Given this list of marker genes PTX3, DUSP1, NPL, HAL, DRAM1, CYP1B1, MARCO, CD63, SMARCD3, STAB1, SDCBP, SERPINA1, C5AR1, S100A8, CHST15, LILRB2, HCAR3, BLVRA, RRAGD, KLF7, F5, EVI2A, PRRG4, FUCA1, SIPA1L1, PILRA, TSPAN14, PLA2G7, HLA-B, MKNK1, ITM2B, PDE6H, ENC1, SLCO3A1, SAT1, HNMT, NCF2, CDA, TMEM127, FTL, LAMP1, ZNF185, PIK3IP1 (phosphoinositide-3-kinase interacting protein 1), GIMAP5, IRAK3, EGR1, IER3, S100A12, GASK1B, MID1IP1 (NCBI Gene Id 58526), SQSTM1, CDC42EP3, PYGL, ELL2, S100A9, ARAP3, FCN1, RIN2, HLA-F, APLP2, IFFO1, ADGRE1 (adhesion G protein-coupled receptor E1), CD68, BST1, LILRA5, HMOX1, ZDHHC7, G0S2, TOM1, SMPDL3A, NCF1C, ASAH1, CYBB, QPCT, FCAR, NAAA, MPP1, CD163, ZFP36L1, CKAP4, VAMP3, KLF2, CNIH4, AGFG1, CYP27A1, SLC11A1, BTG2, PTGER2, RHOA, ARHGEF10L, HLA-A, RTN3, ALDH1A1, CTSB, ATP6AP2, MXI1, CLEC7A, BIN2, APOBEC3A, LIN7A, FCGR2A, MCOLN1, CD36 (NCBI Gene Id 948), METTL9, MSRB1, CEBPB, VNN2, MTMR3, SASH1, SORL1, CXCL1, PSAP, NFKBIA, GIMAP4, LGALS3, CRISPLD2, CREG1, TCF7L2, BEST1, GRK5, TMBIM1, NINJ1, AIF1, LHFPL2, FXYD6, THEMIS2, GLUL, PLBD1, PELI1, PLCB1, SYPL1, BNIP3L (NCBI Gene Id 9257), FRY, LAIR1, CXCL2, EXT1, CXCL8, DUSP6, UBE2D1, PDXK, VCAN, UTRN (utrophin), CDIPT, CD44, SNX2, SIRPB1, CR1, FOLR2, KIAA0513, GLRX, CD46, SOD2, ACSL1, CSF3R, CANT1, STEAP4 (NCBI Gene Id 79689), CTSD, C3AR1, MANBA, CAST, TNFRSF1B, ATP6V1B2, FBN2, FUT4 (NCBI Gene Id 2526), NCF4, ATXN1, TREM1, CLMN, CLIP4, CD14, IGF2R, GNS, NPC2, CTSS, TKT, FBXL5, CTSL, TBXAS1, KIF13B, GIMAP6, PLIN2, LTA4H, ITGAM (NCBI Gene Id 3684), CTSA, NAMPT (NCBI Gene Id 10135), SLC7A7 (NCBI Gene Id 9056), RBMS1, DMXL2, WIPI1, PLXND1, ASGR1, PGD, DYSF, MTARC1, UPP1, DPEP2, SERINC1, SCPEP1, ICAM1, MBD2, here is a description of the gene set: Genes up-regulated in comparison of monocytes from influenza vaccinee at day 7 post-vaccination versus myeloid dendritic cells at day 7 post-vaccination. studied in species Homo sapiens Systems vaccinology has emerged as an interdisciplinary field that combines systems wide measurements and network and predictive modeling applied to vaccinology. Here we used the systems vaccinology approach to study the molecular mechanisms underlying th Human Gene Set: GSE29618_MONOCYTE_VS_MDC_DAY7_FLU_VACCINE_UP from publication Nakaya HI, Wrammert J, Lee EK, Racioppi L, Marie-Kunze S, Haining WN, Means AR, Kasturi SP, Khan N, Li GM, McCausland M, Kanchan V, Kokko KE, Li S, Elbein R, Mehta AK, Aderem A, Subbarao K, Ahmed R, Pulendran B (PMID 21743478)